The following is a description of a gene set: studied in species Homo sapiens We used microarray to compare gene expression between CD161++/CD161+/CD161-CD8+ T cells from human cord blood. Human Gene Set: GSE33424_CD161_HIGH_VS_NEG_CD8_TCELL_UP Genes up-regulated in CD8 T cells: KLRB1 high versus KLRB1-. from publication Walker LJ, Kang YH, Smith MO, Tharmalingham H, Ramamurthy N, Fleming VM, Sahgal N, Leslie A, Oo Y, Geremia A, Scriba TJ, Hanekom WA, Lauer GM, Lantz O, Adams DH, Powrie F, Barnes E, Klenerman P (PMID 22086415), and this is the list of marker genes: GGA2, CIITA, SPOUT1, IREB2, GNA13, SNX2, C9orf85, BLNK, MEF2C, PRKCD, ING4, ARL5A, BIN1, ZC3H12C, ZNF532, FCER2, CCR6, QRSL1, ATF1, TXNDC16, COLGALT1, TOR3A, IDUA, GCNT1, ICAM1, ESRP2, STT3B, UBLCP1, NPY2R, NAPSA, LIMD1, CYRIB, MYCBP2, SERPINB1, VAMP4, HEXA, HLA-DMB, KCTD12, MTPN, BTN1A1, GLCE, IST1, POLM, CD19, CD38, MAPK12, PKIG, PPP1R15B, SERINC3, GANAB, UBL3, MS4A1, AKAP12, HLA-DRB1, CD72, SKAP2, EVI5, TEC, RALGPS2, CD74, MDFIC, ARIH1, UPP1, BCL6, ABCA1, IL10RB, ZFP36L1, INPP1, RAB14, SLC30A5, EPHA6, ATG16L1, MPEG1, CNR2, MIF4GD, PLCG2, SACM1L, GNG10, MYO5A, RHOQ, IGLC7, ADAM10 (NCBI Gene Id 102), NAT1, CD79B, SKIL, ZDHHC14, FICD (FIC domain protein adenylyltransferase), SYK, SPIB (NCBI Gene Id 6689), FCGR1A, PSAP, BIRC3, WBP4, LY86, CXCR5, ASNSD1, HLA-DQA1 (NCBI Gene Id 7946), HCK, INPP5A, EEA1, PCSK5, EIF4G2, RCAN1, LYN, INPPL1, PLBD1, EIF2AK4, SLC30A9, ZNF385A, DNAJA2, CPLX2, CRLF3, STRBP, LYL1, RAB24, SELL, LPGAT1, ALDH1A1, AP1G1, FCGR2B (Fc gamma receptor IIb), RFC1, GRPEL2, CD83, CASP4, CYP4A11, DYRK1A, SYPL1, ITFG1, SLC25A36, FCRLA, MBD4, UIMC1, CD22, PLEKHB2, MGAT1, CTSH, SRPK3, RAB28, HBB, RASSF2, STARD10, OTC, GSTM3, CYFIP1 (NCBI Gene Id 23191), CD40, ZBTB20, POU2AF1, UPF3B, DNAJB9, LUC7L, GNS, TMEM229B (NCBI Gene Id 161145), BCL2A1, CTSC, EID1, HLA-DOB, FIGNL1, CYP2B6, TK2, NCF2, ZNF841, EED (embryonic ectoderm development), KTN1, ERO1B, MYO1E (myosin IE), C1orf43, BLK, AKAP8, SNX9, SMARCA2, CORO2B, HBS1L, PISD, GOSR2, SCAF11, TRNT1, BTK, HSPA4, IRF5, MCL1, SLC25A53, RGS4, TCF4, OAT, UBE2D3, NUCB2, SAFB, CA2, SRGN, SLC4A7, LATS2, SLC44A1, SMNDC1, PKIB, ETS1, ALCAM, IL4I1, SH2B3, HS3ST1, EPB41L2